The following is a description of a gene set: Mouse Gene Set: GOBP_GLUTATHIONE_DERIVATIVE_METABOLIC_PROCESS species: Mus musculus The chemical reactions and pathways involving glutathione derivative., and this is the list of marker genes: Gstp-ps, Gstm6, Gsta1, Gstp3, Gstm3, Gstp1, Gstp2, Gstm1